The following is a description of a gene set: Mouse Gene Set: ZFP712_TARGET_GENES from publication Yevshin I, Sharipov R, Kolmykov S, Kondrakhin Y, Kolpakov F (PMID 30445619) studied in species Mus musculus, and this is the list of marker genes: Ap4m1, Bltp2, Atf7, Angel1, Nufip2, Gm40155, Wapl, 1110002J07Rik, Gm15651, Ccdc107, Krtcap2, Trp53i11, Mtdh (NCBI Gene Id 67154), Arhgef12, Josd1, Gm4349, Atosa, Fth1, Ganc, A930018P22Rik, Cep55, Dgcr8, Trim46, Zbtb44, Trip10, Ogt, Snx14, Prim2, Asl, Nhsl3, Eif3c, Col18a1, Gcc2, Rpain, Dner, Cyb5a, Pgbd1, Efnb2, Clasp1, 9130213A22Rik, Nabp2, Nudt1, Paxbp1 (NCBI Gene Id 67367), Pknox1, Pipox (pipecolic acid oxidase), Cox16, Slc26a11, Chga, Zzef1, Rmrp, Snx27, H2ax, Tshr, Exoc3, Mcm7, C920006O11Rik, I830134H01Rik, Smu1, Cog2, Apela (apelin receptor early endogenous ligand), Etv4, Sgsh, Cep128, Rfx2, Cops4, Lman1, Slc9a8, Slc35b4, Mir8120, Cdk2ap2, Bahcc1, Tut4, Dhx16, Atrnl1, Metrnl, Spsb3, Accs, Nubp2, Cecr2, Mtch1, Nol3, Mrpl14, Crcp, Gm16998 (NCBI Gene Id 100502920), Esrrb, Tbrg1, Uvrag, Alkbh8, Gm9103, Hsd17b11, Foxs1, Gm26330, Tial1, Mbnl2, Brwd1, Tdp2, Spp1, Mccc1, Usp18, Nabp1 (nucleic acid binding protein 1), Snord55, C1qbp, Uvssa (UV stimulated scaffold protein A), Gm3822, Sergef, Stmn1, Pde4d, Ncor2, Birc6, Prdx1, Agtrap, Wrap53, Mfsd12, Ppfibp2 (NCBI Gene Id 19024), Zfp738, H2-M5, 1700019D03Rik, Atf7ip, Gas2l3, Coa7, Gm9506, Narf, Mccc1os, Pdhb, Gm12984, Rell1, Cmtm6, Usp49, A730036I17Rik, Mfsd2a, Brwd3, Ccdc127, Mag, Fam83d, Trim26, Dnali1, Mt2, Gpr108, Arl15, Cenpo, Usp1, Acot13, Eno1, Psma3, Clec2d, Rbck1, Adpgk, Cyb5d2, Oxct1, Gm28888, 4921522P10Rik, Tspan13 (tetraspanin 13), Eda2r, Smg7, Vdac2, Rrn3, Klk1, Spata13, 1700057H15Rik, Fxyd3, Ywhae, Ptrhd1, Man1a, Phf5a, Gspt1 (NCBI Gene Id 98017), Med21, Tsc22d4, Uqcrc2, Mme, 2810403D21Rik, Gm5447, Sntb2, Hltf, Oxct1as (3-oxoacid CoA transferase 1 antisense RNA), Ldhb, Mir1306, Rps8, Ppp4r1, Ndufb2, Cyp4f13, Rheb, A130010J15Rik, Ehbp1, Gm16096, 4930461C15Rik, Sirt3, Gnl3, Mbtps2, Gtf2a1, Tram1, Cyp2s1, Snhg5, Serhl, Ipmk, Rex1bd, Arf4, Dsc1, Mllt6, Dclk1, Actr2, Crot, Pank2, Mrm2, Kctd7, 5730522E02Rik, Gpi1, Nr2c2, Slc25a36, Srp68, Rabgap1, Cab39, Aco2, Gm28047 (predicted gene, 28047), Mir3618, Hps3, Dcbld2, Atp8b3, Mis18bp1, Stk31, Snip1, Tmem192, Mir1945, Ccser2, Akap7, Dtl (NCBI Gene Id 76843), Ccnl1, Smarca2, 4933421A08Rik, Cap1, Rfwd3, Cnpy1, Mpp7, Arid5a, Septin9, Igfbp2, Gm16046, Psmd13, Nipsnap1, Spock2, Kpnb1, Gfus, Platr22 (pluripotency associated transcript 22), Gm12100, Skic3